Given this list of marker genes Prkcq, Nfkbiz, Malt1, Ccr6, Il4, Ascl2, Notch1, Tnfsf18, Phb1, Tgfb1, Brd2, Tbx21, Mir326, Zbtb7b, Nlrp3, Il6ra, Ep300, Slamf6, Zc3h12a, Mir873a, Jak2, Nlrp10, Il2, Ephb2, Arid5a, Entpd7, Lgals1, Loxl3, Cd69, Lgals9, Il23a, Rorc, Opa1, Otud5, Irf4, Tyk2, Il6, Il17ra, Smad7, Foxp3, Ly9, Traf3ip2, Mir301, Card9, Pf4, Rc3h1, Nfkbid, Il27ra, Clec4n, Clec7a, Ccl20, Stat3, Rora, Batf, Rc3h2, Brd4, here is a description of the gene set: Mouse Gene Set: GOBP_T_HELPER_17_TYPE_IMMUNE_RESPONSE An immune response which is associated with resistance to intracellular bacteria with a key role in inflammation and tissue injury. This immune response is associated with pathological autoimmune conditions such as multiple sclerosis, arthritis and psoriasis which is typically orchestrated by the production of particular cytokines by T-helper 17 cells, most notably interleukin-17, IL-21 and IL-22. species: Mus musculus